The following is a description of a gene set: species: Homo sapiens Shortening of the legs related to developmental hypoplasia of the bones of the leg. Short lower limbs Human Gene Set: HP_SHORT_LOWER_LIMBS, and this is the list of marker genes: ADNP, LAMA5, FN1, EXT2, EXT1, COL2A1, MMP13 (NCBI Gene Id 4322), PPIB, ALPL, GNA11, ARL6IP6, NOG, SLC26A2